The following is a description of a gene set: studied in species Homo sapiens from publication Dower K, Ellis DK, Saraf K, Jelinsky SA, Lin LL (PMID 18292579) TREM-1 is an orphan immunoreceptor expressed on monocytes, macrophages, and neutrophils. TREM-1 associates with and signals via the adapter protein DAP12/TYROBP, which contains an immunoreceptor tyrosine-based activation motif (ITAM). TREM-1 activation by receptor cross-linking is pro-inflammatory, and can amplify cellular responses to Toll-like receptor (TLR) ligands such as bacterial lipopolysaccharide (LPS). To investigate the cellular consequences of TREM-1 activation, we have characterized global gene expression changes in human monocytes in response to TREM-1 cross-linking in comparison to and combined with LPS. Both TREM-1 activation and LPS up-regulate chemokines, cytokines, matrix metalloproteases, and PTGS/COX2, consistent with a core inflammatory response. However, other immunomodulatory factors are selectively induced, including SPP1 and CSF1 (i.e., M-CSF) by TREM-1 activation and IL-23 and CSF3 (i.e., G-CSF) by LPS. Additionally, cross-talk between TREM-1 activation and LPS occurs on multiple levels. While synergy in GM-CSF protein production is reflected in commensurate mRNA abundance, comparable synergy in IL-1b protein production is not. TREM-1 activation also attenuates the induction of some LPS target genes, including those that encode IL-12 cytokine family subunits. Whereas positive TREM-1 outputs are abolished by the PI3K inhibitor wortmannin, this attenuation is largely PI3K-independent. These experiments provide a detailed analysis of the cellular consequences of TREM-1 activation, and highlight some of the complexity in signal integration between ITAM- and TLR-mediated signaling. Human Gene Set: GSE9988_ANTI_TREM1_VS_LPS_MONOCYTE_UP Genes up-regulated in comparison of monocytes treated with anti-TREM1 versus monocytes treated with 5000 ng/ml LPS (TLR4 agonist)., and this is the list of marker genes: EMP1, ZC3HC1, ZBTB43, LONRF3, ID3, IFI30, ATP6V1G1, DHRS9 (dehydrogenase/reductase 9), TRIB1, BLOC1S3, LHFPL2, NRBP1, PLEKHO2, ARID5A, MOAP1, PHAF1, TGIF1, TCEAL9, ADCK2 (aarF domain containing kinase 2), LASP1, RABGEF1, SMIM29, PI4K2A (phosphatidylinositol 4-kinase type 2 alpha), VKORC1, MAPKAPK3, COL15A1, JMJD1C, FNIP2, TSC22D3, GFOD1, ORAI3, LYSET, DTL, ATOSB, LBX2-AS1, PPFIA1, PEX5, TMEM121B, SGK1, TNFRSF12A, SPART, CTSL, HAVCR2, DAB2, AVPI1, FBXL5, AKIRIN2, TMBIM1, KCTD7, WDR91, HOMER3, TXNIP, DOK2, MT1E, CD164, SLC17A5, MCOLN1, ATP6V1B2, ACVR1, IMP3, BCAR3, SEC22C, FAM83G, CHSY1, MELTF, UBASH3B, RNASEK, PLEKHM1, S100A2, ASPH, FKBP15, SDS, RREB1, ZBTB21, BRI3, TGFBR1, LIMK1, RSC1A1, VPS37B, SNUPN, COA7, OLIG2, CHKA, MAP4K3, ABCG1, TSHZ1, TBC1D2, NDUFB2, RIOK3, TNFSF14, SLC37A2, PGS1, LRFN4, STX4, TLE3, LPL, CSNK1D, SCARB2, SLC8B1, HIC1, SGSH, SMIM13, TMEM273, LPIN1, CYTH4, ZCCHC2, OLIG1, CNST, GTF2IRD1, NAA50, NRIP3, RHOB, PHF13 (PHD finger protein 13), MIEF1, BCAP31, NPC1, NRROS, KLHL26, SPRY2, KBTBD8 (NCBI Gene Id 84541), MMP19, TM2D2, STX3, RAP2B, EIF2AK3, AMD1, CCDC97, PLCXD1, LINC01010, CEBPB (NCBI Gene Id 90277), SH3BP5, SDSL, SLC26A2, KLF2, SNX33, TMEM70, SH3BGRL3, GGA2, SPP1, USP38, LONP1, SNX12, RRAGC, RRAGD, KLHL6, LGALS3, TMEM38B (NCBI Gene Id 55151), PLEKHM2, BAG3, PSD4, GNPDA1, PPARG, CAMSAP1, LY9, TLNRD1, FBXO7, MIR22HG, GABARAP, HSD3B7, STX1A, SLC1A4 (NCBI Gene Id 6509), CCR1, CD37, HEXB, NRBF2, CORO1C, ITGAX, TBC1D7, ANKRD28, AFF1, NDUFB9, CLN8, PHF23, GATAD2A, RARA, MAP1LC3B, DUSP14, UBR7, TPCN2, PLPP3, ACSL3, GPCPD1, PLEKHO1, PTPN6, DYNLT2B, S1PR3, IL17RA, TNFSF15 (TNF superfamily member 15), DNMBP, RIC8A, CHST15, SYN2, MACIR, MGAT1, ATF3, CRTAM, SERTAD1, TUT7 (NCBI Gene Id 79670)